The following is a description of a gene set: Any process that modulates the frequency, rate or extent of cell morphogenesis. Cell morphogenesis is the developmental process in which the shape of a cell is generated and organized. species: Homo sapiens Human Gene Set: GOBP_REGULATION_OF_CELL_MORPHOGENESIS, and this is the list of marker genes: RHOU, RREB1, RELN, EZR, NTNG1, PARP6, SEMA4A, MYH14, PLXNB3, PLXND1, CPNE5, FGR, NEDD4L, SH3D19, DVL2, FGD4, PALMD, SPAG9, CFL1 (NCBI Gene Id 1072), CDC42EP4, FGD6, BRWD3, SYT4, ZNF135, TAOK2, OBSL1, CNTN2, MKLN1, CDKL5, ANXA1, PLAA, EPS8, FYN, ANKRD27, MYO10, CCL3, PALM, ZMYM3, SEMA4D, FZD4, RHOBTB2, SHROOM3, MARK2, PTPRD, FMNL1, FES, SLC23A2, SS18L1, FGD3, CDC42EP5, CDC42SE1, RIMS2, LARP4, RHOBTB1, PRAG1, DIAPH1, SPRY3, PARVG, SYT17, ANAPC2, CCL11, KANK1, MOV10, RIMS1, STRIP1, CAMSAP1, PALM3, EPHB2, MYO9A, GAS2, WNT5A, DLG4, RAC1, FMNL2, CDC42EP2, MAP3K13, BAIAP2, ATG16L1, FBXW8 (F-box and WD repeat domain containing 8), MYH10, ARHGEF7 (Rho guanine nucleotide exchange factor 7), ITGB2, RASA1, SEPTIN7, MYL12B, ZRANB1, MIR21 (NCBI Gene Id 406991), BCL9L, F11R, CSF1R, CUX1, SMURF1, IL1RAPL1 (interleukin 1 receptor accessory protein like 1), GNA12, ERMN, CRK, S100B, ARAP1, PDPN, ITGA7, CDKL3, FMNL3, PRKN, ARHGAP35, SYT3, PLXNB2, MSN, ITSN2, ARHGAP15, SYNE3, CPNE6, CCL13, CUL7 (NCBI Gene Id 9820), TBC1D24 (NCBI Gene Id 57465), RDX, DLG1, CORO1A, RAB21, CLDN4, LST1, VIL1, ENPP2, ITPKA, PDZD8, CCL7, SH3KBP1, SPTA1, ZMYM4, CAPZB, COCH, PARVA, CORO1C, HEXB, NTNG2, FERMT2, FAM171A1, ARPIN (actin related protein 2/3 complex inhibitor), PLEKHO1, CD44, KIT, PHIP, PTK2B, DVL1, SYT14P1, DMTN, FGD5, ZMPSTE24, CACNG7, FGD1, CFDP1, DBN1, CCL24, ZMYM6, PLXNB1, WTIP, LIMD1, RNF157, NHERF1, FGD2, EPB42, SLC26A5, DAPK3, P2RY1, PRPF40A, BVES, SRC, ATP10A, CLDN3, EFNA5, HCK, ARHGAP18, MPL, ARHGEF18, LPAR1, EEF2K, DHX36, PARVB, EPHA4, DVL3, CORO1B, MUL1, SLC30A1, CAPRIN2, DNMBP, ARC, CDC42EP3 (NCBI Gene Id 10602), CAPRIN1, AGO4, TBCCD1, FITM2, VEGFA, RAC3, CDC42EP1, CAMK2B, FN1, STRIP2 (NCBI Gene Id 57464), PLXNC1, ALDOA (aldolase, fructose-bisphosphate A), NF2, TPM1, NUMBL, ARMCX5-GPRASP2 (ARMCX5-GPRASP2 readthrough), SYT2, MYH9, MFSD2A, C15orf62, CYFIP1, RHOJ, UNC13A, RASAL1, SPARC, PALM2AKAP2, RHOG, KDR, GRIP1, HPN, PRKDC, OSTN, EPB41L3, CCL2 (C-C motif chemokine ligand 2), GNA13, BCL11A, PTK2, CFAP410, CDC42SE2, HDAC6, PEAK3, GPRASP3, SEMA3E, WASF3, RHOQ, WDR1, F2, FBLIM1, CUX2, SYT1, LRP8, YPEL4, STAU2, BAMBI, MACF1, WDPCP, CPNE9, BRWD1, PAFAH1B1, RAC2